The following is a description of a gene set: studied in species Homo sapiens The transcriptome of naive OT-I T cells was compared to memory CD8 T cells after 1, 2, 3, or 4 infection with ovalbumin expressing Listeria monocytogenes (LM-OVA). from publication Wirth TC, Xue HH, Rai D, Sabel JT, Bair T, Harty JT, Badovinac VP (PMID 20619696) Human Gene Set: GSE21360_SECONDARY_VS_QUATERNARY_MEMORY_CD8_TCELL_DN Genes down-regulated in memory CD8 T cells: 2' versus 4'., and this is the list of marker genes: CEMIP2, SNN, ENO1, GRHPR, MAP4K4, EDNRB, RIPOR2, HOXA2 (NCBI Gene Id 3199), GGT1, EGLN3, PRELID1, SMARCE1, LDHA, ACE2, ZC3H12D, PIK3CG, CTSC, KDM4B, LRG1, TWF1, TNFSF9, HIF1A, STK17B, ARRDC4, RASA2, IFITM1, CYRIB, NDUFV3, EMILIN2, RTCA, SAR1B, PGK1, EIF4EBP1, LCP2, POLR1G, C1RL, CCDC83, DDIT4, TMEM176B, KDM5B, GRINA, MAGED1, DKK3, HK2, BST1, SLC2A1, SRGN, FICD, ATRNL1, MIR128-2, ARHGAP4, DTL, SNX6, TXLNB, DSC1, GPR171, SLC16A6, CATSPERB, SEMA4C, ABCA12, TUBA1A, SOCS3, RNF141, FBXO22, TMEM63A, THBS1, NRP2, TGFBI, ITGAM, NRIP1, PLA2G4A, SYCE2, UHRF1, LIPG, JCHAIN, FAM169BP, ENO2, RELT (NCBI Gene Id 84957), NBL1, TNFAIP8, MIF, POLR2D, PGM2, PTPN7, NFIL3 (nuclear factor, interleukin 3 regulated), CCND3, SLC39A1, LIPC, PKM, SGCZ, RAB11A, NDRG1, GIMAP1, EID1, PFKL, LAMC1, EIF4E, SLC16A3, PSTPIP1, PRELID2 (NCBI Gene Id 153768), IFI27L1, TRIM10, TREM1, PGAM1, TMEM176A, SLA, TMEFF1, CD81, FAM162A, DISC1, DMWD, MTHFD1L, UBE2I, P4HA1, OAF, SFXN1, QSOX1, ABCA1, RBPJ, ERO1A, PDPN, BPNT1, GRAMD1A, BNIP3, SNX18, ATG5, NOS2, ALDOC, SMAD3, SLC39A14, PYGL, GALNT2, CAMKK1, CCND2, ARG1, FGR, GPC3, VAV1 (vav guanine nucleotide exchange factor 1), HOOK1, PTBP1, MARCHF1, EEFSEC, VEGFA, FBXL5, RAVER1, JMJD6, TPI1, EGLN1, STAT3, ARID5A, CLDND1 (NCBI Gene Id 56650), GYS1, SMCO4, PIGQ, PTPN1, CD38 (CD38 molecule), CIAO2A, TCF3, ADAM15, NARF, PPP1R13L, SEMA4A, CHSY1, PDK1